Given this list of marker genes MIR125B1, CSF1, SOX4, PRKCI, IDH2, ORC3, SKI, TNF, UFL1, GFAP, PENK, SOX11, GBA1, NDP, KRAS, NFIB, HES1, NF2, ABCC8, TSPO, NFIA, MIR221, DICER1, MYB, MIR146A, ASCL2, ATXN1, CHRM1, CERS2, IL6, IL1B, LGI4, CX3CL1, IL33, LTA, PPP1CC, NF1, EEF2, LEPR, TP53, MECP2, E2F1, RNF10, EPM2A, SOX10, TREM2, LYN, CREB1, NOTCH1, CLU, VEGFC, AREG, MIR222, CSF1R, PRKCH, RB1, NTN1, SHH, ETV5, SLC7A5, IL34, PLAG1, here is a description of the gene set: The multiplication or reproduction of glial cells by cell division, resulting in the expansion of their population. Glial cells exist throughout the nervous system, and include Schwann cells, astrocytes, and oligodendrocytes among others. studied in species Homo sapiens Human Gene Set: GOBP_GLIAL_CELL_PROLIFERATION